Given this list of marker genes PTPN21 (protein tyrosine phosphatase non-receptor type 21), DRD1, AQP1, ELMO1, GPR18, HCAR1, ACVRL1, ATXN3, EPHB1, GRK5, COL4A4, RORA (NCBI Gene Id 6095), BHMT, DPYS, ALPG, here is a description of the gene set: studied in species Homo sapiens Genes in the cancer module 571. Human Gene Set: MODULE_571